Given this list of marker genes CHRNA10, CHRNA2, CHRNA7, CHRNG, P2RX1, SLC1A7, CHRNA5, GLRA2, CHRNA6, GLRA1, P2RX3, CHRNB3, HTR3D, CHRNB2, HTR3E, CHRNA4, CHRNB4, CHRNA1, HTR3C, CHRFAM7A, HTR3B, CHRNE, CHRND, P2RX6, GLRA3, CHRNA3, P2RX5, P2RX7, GRIK2, CHRNA9, CHRNB1, P2RX4, HTR3A, GLRB, P2RX2, SLC17A7, TRPV1, here is a description of the gene set: Human Gene Set: GOMF_EXCITATORY_EXTRACELLULAR_LIGAND_GATED_MONOATOMIC_ION_CHANNEL_ACTIVITY Enables the transmembrane transfer of an ion by a channel that opens when a specific extracellular ligand has been bound by the channel complex or one of its constituent parts, where channel opening contributes to an increase in membrane potential. species: Homo sapiens